The following is a description of a gene set: Any process that activates or increases the frequency, rate or extent of mitochondrial outer membrane permeabilization involved in apoptotic signaling pathway. Human Gene Set: GOBP_POSITIVE_REGULATION_OF_MITOCHONDRIAL_OUTER_MEMBRANE_PERMEABILIZATION_INVOLVED_IN_APOPTOTIC_SIGNALING_PATHWAY studied in species Homo sapiens, and this is the list of marker genes: GSK3B, CHCHD10, ZNF205, HIP1R, ATP5IF1, LRRK2, SIVA1, BOK (NCBI Gene Id 84558), BAK1, GSK3A